The following is a description of a gene set: Mouse Gene Set: GOBP_POSITIVE_REGULATION_OF_PROTEIN_LOCALIZATION_TO_EARLY_ENDOSOME Any process that activates or increases the frequency, rate or extent of protein localization to early endosome. studied in species Mus musculus, and this is the list of marker genes: Sorl1, Mgat3, Vegfa, Ezr, Nf2, Rock2, Rdx, Dtx3l, Egfr (NCBI Gene Id 13649), Msn, Egf